The following is a description of a gene set: B lymphocyte late differentiation genes (LDG): top genes down-regulated in plasma cells from tonsils (TPC) compared to those from bone marrow (BPC). from publication Zhan F, Tian E, Bumm K, Smith R, Barlogie B, Shaughnessy J Jr (PMID 12393520) To identify genes linked to normal plasma cell (PC) differentiation and to classify multiple myeloma (MM) with respect to the expression patterns of these genes, we analyzed global mRNA expression in CD19-enriched B cells (BCs) from 7 tonsils, CD138-enriched PCs from 11 tonsils, 31 normal bone marrow samples, and 74 MM bone marrow samples using microarrays interrogating genes. Hierarchical clustering analyses with genes clearly segregated the 4 cell types, and chi-square and Wilcoxin rank sum tests (P <.0005) identified 359 and 500 previously defined and novel genes that distinguish tonsil BCs from tonsil PCs (early differentiation genes), and tonsil PCs from bone marrow PCs (late differentiation genes), respectively. MM as a whole was found to have dramatically variable expression of EDGs and LDGs, and one-way analysis of variance (ANOVA) was used to identify the most variable EDGs (vEDGs) and LDGs (v1LDG and v2LDG). Hierarchical cluster analysis with these genes revealed that previously defined MM gene expression subgroups (MM1-MM4) could be linked to one of the 3 normal cell types. Clustering with 30 vEDGs revealed that 13 of 18 MM4 cases clustered with tonsil BCs (P =.000 05), whereas 14 of 15 MM3 cases clustered with tonsil PCs when using 50 v1LDG (P =.000 008), and 14 of 20 MM2 cases clustered with bone marrow PCs when using 50 v2LDG (P =.000 09). MM1 showed no significant linkage with normal cell types studied. Thus, genes whose expression is linked to distinct transitions in late-stage B-cell differentiation can be used to classify MM. Human Gene Set: ZHAN_LATE_DIFFERENTIATION_GENES_DN species: Homo sapiens, and this is the list of marker genes: MYBL1, EPHX1, IRAG2, CKS2, BCL6, SORL1, TCEA1, KLK1, RHOH, SYK, MARCKSL1, BORCS8-MEF2B, LCK, BIK, GPR183, PKM, ADA